Given this list of marker genes DAO, AOC2, AOC3, MAOA (NCBI Gene Id 441491), MAOB, DDO, IL4I1, AOC1, VCAM1, here is a description of the gene set: Human Gene Set: GOMF_PRIMARY_METHYLAMINE_OXIDASE_ACTIVITY studied in species Homo sapiens Catalysis of the reaction: a primary methyl amine + H2O + O2 = an aldehyde + H2O2 + NH4+.